The following is a description of a gene set: Human Gene Set: HP_RETINOPATHY_OF_PREMATURITY Retinopathy of prematurity An avascular or abnormally vascularized retina that occurs in premature infants and can lead to blindness. studied in species Homo sapiens, and this is the list of marker genes: THSD1, FZD4, NDP, DBR1, LRP5